The following is a description of a gene set: Human Gene Set: MIR3686 from publication Chen Y, Wang X (PMID 31504780) species: Homo sapiens Genes predicted to be targets of miRBase v22 microRNA hsa-miR-3686 in miRDB v6.0 with MirTarget v4 prediction scores > 80 (high confidence targets)., and this is the list of marker genes: AMPH, MCL1, EIF3J, SLC6A15, XPO7, PHYHIPL, SLAIN2, SLC30A7, PSTPIP2, ABAT, KLF12, SKP2, UNC119B, EEPD1, EML5, RECK, PARVA, DAGLA, BCKDHB, HMGCS1, PPFIA1, SETD9, SLC38A1, EGFL8, GPBP1L1, DHRS12, NDC1, ASCC3, GAS6, RASAL2, ZNF124, ARSJ, NAA15, SLC30A8, SLC15A4, AP3M1, CHD9, CYP4V2, CACNA2D2, HOMER1, KDM4C, MAGI2, SEC24D, ZMYND8, C7orf57, EIF3A, MICAL2, N4BP2, FMO2, DGKH, DBF4, DENND11, IMPACT (impact RWD domain protein), ANO4, SYNJ1, C11orf58, CDHR1, ATP8B1, ZIC1, MACO1, FOXN3, PLAGL1, CDK9, CNTNAP3B, C5orf24, TNRC6C, ECE2, PPP4R1, NRIP1, L3MBTL3, GLUL, SLC25A12, ANAPC16, RAI14, XRN2, RPRD1A, SH3GLB1, TRIM71, OSBPL8, PALM2AKAP2, SIPA1L2, PHIP, TUT4, SMG1, PCDH7, ZMYM5, LCOR, GHSR, NAP1L4, FJX1, ZC3H12C, BCAS1, UNKL, DCX, SLC12A6, PHC3, UBXN2B, HDHD2, C6orf120, RAC1, ACYP2, PKHD1, ZNF148, TRIO, ERCC1, C2orf49, ADAMTS5, PHACTR2, RSPH4A, FAM222B, DKK2, EML4, VPS50, IGFBP7, SPRY3 (NCBI Gene Id 253479), SLC38A4, ATXN7L1, FMNL3, KDM3A, GPRASP3, NBR1, LRCH2, MINPP1, SSH2, ALG14, LIN54, NAA35, WDR82, EPC1, AP4S1, LZTFL1 (leucine zipper transcription factor like 1), PNPLA8, A1CF, PLAGL2, RAB6C, COTL1, WIPI2, MCTP1, STOX2, LRP8, ZFP36L2, SLC22A23, NCKAP5, KDELR1, PTPRD, SLC30A4, TOMM40, ARHGAP12, PLA1A, HIPK4, FGD4, TMEM108, COL4A5, RAB8B, AEBP2, PUM2, MRPL3, LSM8, COL13A1, ZNF471, ABCD3, METTL4, EDNRA, USP32, ITGAD, LRP11, NR2F2, USP42, HHIP, GPATCH2L, ARAP2, THRB, SDC2, RBM12, ATAD2B, LRP6, B3GNT5, UBE2D1, LMBR1, CD244, TUSC3, QPCT, ATP11C (ATPase phospholipid transporting 11C), ABCA1, MYZAP, TPO, IRS2, IFNA2, WDR41 (NCBI Gene Id 55255), PPP2R5D, NEXMIF, ESCO1, DRG2, ZMYM2, POFUT2, SLC30A5, TMTC1, ZMAT1, SSX2IP, BRWD1, BAZ1A, PHF12, RBM5, PIAS2, HDGFL3, NDRG3, KDM6A, POLH, MMD, ARHGEF33, CHIC1, BBOF1 (NCBI Gene Id 80127), LYZ, TFB1M, TGFBR1, ZNF516, VPS41, JDP2, NR6A1, IRX2, PEAK1, CALML4, UBN1, ANKRD22, EOGT, EEF1AKMT4-ECE2, C10orf88, SLCO6A1, MAF, TNRC6A, MICU3, TRIQK, PSD3, KRTAP4-6, RAMAC, HAUS1, RIPOR1, KIF2A, SAMTOR, ARHGEF3, KLHL36, ANKRD28, PHF24, GRAMD1B, MALT1, JAG2, PRKG1, TCF7L2, PRRG1, MXRA5, SYNPO2, ZFYVE9, LCORL, PIP5KL1, ASAH1, KLF9, QKI, TMA16, NEUROD1, SELENOF, CECR2, PEG3, FUNDC2, LIMCH1, ARHGAP28, PRRC2C, TSLP, ZNF737, GPHN, EXOC6, ARFGEF1, TMEM248 (transmembrane protein 248), NUFIP2, TBL1XR1, ABCC9, PPP2R3A, RBBP6, ELP4, NWD2, WDR86, PLXDC2 (NCBI Gene Id 84898), FUT9, SH2B3 (SH2B adaptor protein 3), C2CD6, DENND1B (NCBI Gene Id 54530), NRP1, SCN1B, CA5B, ABHD5, TMX3, PYROXD1, EZR, ERG, PPHLN1, KIAA1217, ERO1A, MSTN, IRAG1, ZNF287, CPNE4, SPATA6, GUCY1A2 (guanylate cyclase 1 soluble subunit alpha 2), XRCC2, DENND4A, MED13, VPS54 (NCBI Gene Id 51542), RFX3 (regulatory factor X3), ATP5F1A, TNF, TVP23B, HMG20A, UPP2, ZNF684, FZD1, TAF1A, CREBZF, RASL11B (NCBI Gene Id 79093), BMP2, NKX2-2, SLF2, ONECUT2, NR0B2, PLPPR1, NPAT (nuclear protein, coactivator of histone transcription), BCOR, KRIT1, EPPK1, FMNL2, GGNBP2, SPAST, MOSPD1